The following is a description of a gene set: Mouse Gene Set: GOBP_NEUTRAL_LIPID_BIOSYNTHETIC_PROCESS studied in species Mus musculus The chemical reactions and pathways resulting in the formation of neutral lipids, lipids only soluble in solvents of very low polarity., and this is the list of marker genes: Ang5, Agmo, Awat2, Ang2, C3, Dgat2l6, Acsl4 (acyl-CoA synthetase long-chain family member 4), Tcf7l2, Gpam (glycerol-3-phosphate acyltransferase, mitochondrial), Mfsd2a, Gpat2, Avil, Daglb, Acsl1, Lpin3, Thrsp (thyroid hormone responsive), Tmx1, Sirt1, Ang, Pnpla2, Pla2g15, Nr1h2, Cnep1r1, Scarb1, Ctdnep1, Lpin1, Nr1h4 (NCBI Gene Id 20186), Dgat2, Dgat1, Agpat2, Lpl, Rgn, Rbp2, Pck2, Acsl6, Ang6, Lpgat1, Plce1, Gpat4, Mogat1, Nr1h3, Mogat2, Lpin2, Kat5 (K(lysine) acetyltransferase 5), Gk, Plin5, Sik1 (NCBI Gene Id 224682), Plpp1, Apoc3, Slc27a1, Pla2g4a, Acsl5, Tmem68, Gpat3, Srebf1, Ang4, Dagla, Pck1, Gpld1, Pnpla3, Ldlr